The following is a description of a gene set: studied in species Mus musculus Genes predicted to be targets of miRBase v22 microRNA mmu_miR_147_3p in miRDB v6.0 with MirTarget v4 prediction scores > 80 (high confidence targets). from publication Chen Y, Wang X (PMID 31504780) Mouse Gene Set: MIR_147_3P, and this is the list of marker genes: Ndufa4, Fam222a, Tmem117, Alyref2, Prkcz, Zwilch (NCBI Gene Id 68014)